Given this list of marker genes Dock6, Tuba1a (NCBI Gene Id 22142), Dock9, H3c3, Kif1a, Carmil1, Kif13b, Cenpe, Akap10, Gata6, Vps45, Tuba3a, Kifc5b, Mfn1, Kif16b, Ehd3, Itpk1, H3c8, Dock2, Phf21a, Capza2, Kif2b (kinesin family member 2B), Kif20a (kinesin family member 20A), Kif3a, Kif15, Cdc42, Prkar1a (protein kinase, cAMP dependent regulatory, type I, alpha), Zfpm2, Mafk, Kif9, H3c10, Dock11, Kifc1, Rad51c, Tuba1c, H3f3b, Klc4, Mfn2, H3c14, Hdac1, Tuba3b, Kif26a, Kif21a, Gata2, Jmjd1c, Kif3c, H3c2, Zfpm1, Sh2b2, Jak2, Kif12, Tubb1, Kif2c, Gata4, Tuba1b, Tubal3, Gata5, Tuba4a, Kif3b, Sh2b1, Hmg20b, Kdm1a, Kif5b (NCBI Gene Id 16573), H3c15, Dock5, Dock4, Kif22, Klc2, Kif27, Prkacb, H3c1, Dock1, Kifc2, Tubb3, Klc3, Kif5a, Rac1, Cbx5, H3c7, Kif28, Kif1c, Dock10, Prkar1b, Ehd2, Akap1, Gata3, H3c11, Kif11, Kif18a, Kif23, Klc1, Kif26b, Tubb6, Tubb4b, H3c4, Rad51b, Tubb4a, Kif6, Rbsn, H3f3a, Dock7, Kif1b, Kif2a, Kif21b, Prkaca, H3c6, Sh2b3, Kifap3, Capzb, Rab5a, Racgap1, Mafg, Gata1, Kif20b, Rcor1, Tubb2b (NCBI Gene Id 73710), Kif4, Tubb2a, Kif19a, Kif18b, Ehd1, Maff, Ak3, H3c13, Tuba8, Dock8, here is a description of the gene set: Mouse Gene Set: REACTOME_FACTORS_INVOLVED_IN_MEGAKARYOCYTE_DEVELOPMENT_AND_PLATELET_PRODUCTION Factors involved in megakaryocyte development and platelet production species: Mus musculus